Given this list of marker genes Itgav, Itgb3, Abl1, Sox8, Hpse, Cthrc1, Gata1, Igf1r, Ccn1, Lrp5, Ltf, Gsk3b, Bmp2, Fbln5, Tmem119, here is a description of the gene set: studied in species Mus musculus Mouse Gene Set: GOBP_POSITIVE_REGULATION_OF_OSTEOBLAST_PROLIFERATION Any process that activates or increases the rate or extent of osteoblast proliferation.